The following is a description of a gene set: Mouse Gene Set: REACTOME_SPHINGOLIPID_DE_NOVO_BIOSYNTHESIS Sphingolipid de novo biosynthesis studied in species Mus musculus, and this is the list of marker genes: Sgms1, Ormdl2 (NCBI Gene Id 66844), Cers2, Degs1, Cyb5b, Sgms2, Sptssb, Ormdl3, Kdsr, Cers1, Sphk1, Sptlc1, Cers6, Sptssa, Fa2h, Ormdl1, Sphk2, Sptlc3, Abcc1, Degs2, Sptlc2, Cers5, Spns2, Cers3, Samd8, Cers4, Mfsd2b